Given this list of marker genes NAP1L3, H1-6, H2BC21, H2AC8, CHAF1B, H2BC11 (H2B clustered histone 11), H1-0, H2AZ1, H1-1 (H1.1 linker histone, cluster member), H2AX, H1-2, H2BC12, H2BC13, H2AC18, H2AC6, CHAF1A, CENPA, here is a description of the gene set: Genes in the cancer module 90. Human Gene Set: MODULE_90 studied in species Homo sapiens